The following is a description of a gene set: The binding by a cell-adhesion protein on a cell surface to an adhesion molecule on another cell surface or an external substrate, to mediate adhesion of the cell to the external substrate or to another cell. Mouse Gene Set: GOMF_CELL_ADHESION_MEDIATOR_ACTIVITY studied in species Mus musculus, and this is the list of marker genes: Gldn, Lrrc4c, Izumo1, Itga10, Nectin1, Cntn5, Jam3, Esam, Epcam, Nfasc, Itga1, Cntn2, Mcam, Cxadr (NCBI Gene Id 70446), Bsg, Madcam1, Ninj1, Cd200, Cd200l2, Cd200r1, Cd47, Lama5, Nectin3, Emb, Mypn, Dscaml1, Cd200l1, Dscam, Emilin1, Rpsa, Cntn6, Cdh5, Myot, Mip, Plxnb3, Svep1, Ppp1ca, Nptn, Itga9, Sirpa, Cdh9, Tmigd1, Prtg, Nexn, Ctnnd1, Igsf9, Ager, Itgb1, Bcam, Itga11 (NCBI Gene Id 319480), Nrcam, Vcam1, Cntn1, Itga2, Slamf1, Ntng1, Clstn3